Given this list of marker genes Kctd12, Adrb1, Grid1, Kctd16, Gabbr1, Grm1, Grm5, here is a description of the gene set: A G protein-coupled receptor activity occurring in the postsynaptic membrane that is part of a GPCR signaling pathway that positively regulates ion channel activity in the postsynaptic membrane. studied in species Mus musculus Mouse Gene Set: GOMF_G_PROTEIN_COUPLED_RECEPTOR_ACTIVITY_INVOLVED_IN_REGULATION_OF_POSTSYNAPTIC_MEMBRANE_POTENTIAL